Given this list of marker genes Psmd6, Psmd12, Pabpc1, Psmb4, Psma3, Psma7, Psma2, Psmc2 (NCBI Gene Id 19181, proteasome (prosome, macropain) 26S subunit, ATPase 2), Psma4, Psmc6, Ubb, Psmd1, Psmd13, Psmc5, Psma1, Psmc3, Psmc4 (proteasome (prosome, macropain) 26S subunit, ATPase, 4), Hspb1, Psmd7, Psma6, Psmb6, Psmb5, Psma5, Psmb7, Psmc1, Rps27a, here is a description of the gene set: This event has been computationally inferred from an event that has been demonstrated in another species.<p>The inference is based on the homology mapping from PANTHER. Briefly, reactions for which all involved PhysicalEntities (in input, output and catalyst) have a mapped orthologue/paralogue (for complexes at least 75% of components must have a mapping) are inferred to the other species. part of: Regulation of mRNA stability by proteins that bind AU-rich elements Reactome Pathway: AUF1 (hnRNP D0) binds and destabilizes mRNA electronically inferred by orthology from the curated human pathway studied in species Mus musculus